The following is a description of a gene set: One of two multimeric complexes that forms a membrane vesicle coat. The mammalian COPI subunits are called alpha-, beta-, beta'-, gamma-, delta-, epsilon- and zeta-COP. Vesicles with COPI coats are found associated with Golgi membranes at steady state. Human Gene Set: GOCC_COPI_VESICLE_COAT studied in species Homo sapiens, and this is the list of marker genes: COPE, COPG2, COPA, DIPK2A, TMED3, COPZ2, SCYL1, COPB1, COPG1, ARCN1, TMED7, COPB2, COPZ1